Given this list of marker genes Zc3h4, Nelfa, Supt5, Med27, Cdc73, Ccnt2, Scaf8, Supt4a, Ikzf1, Med24, Hnrnpu, Ell2, Wdr43, Med14, Btbd18, Supt4b, Med10, Ccnk, Nelfcd, Wdr82, Ctnnb1, Med25, Leo1, Nelfe (NCBI Gene Id 27632), Cdk12, Nelfb, Med19, Supt6, Hexim1, Med6, Zmynd11, Gtf2f1, Map2k1 (NCBI Gene Id 26395), Cbx7, Med21, Med16, Ccnt1, Ldb1, Med11, Med1, Med20, Med22, Med23, Ncbp1, Sirt6, Ccar2, Ell, Cdk9, Eapp (E2F-associated phosphoprotein), Zmynd8 (NCBI Gene Id 99150), Eaf2, Ncbp2, Med17, Shh, Med7, Med9, Tex24, Med26, Med4, Ezh2, Setd5, Brd4, Med18, Cdk13, Dab2, Ell3, Parp1, Axin1, Eaf1, Med30, Med8, Med31, Recql5, Rnf8, Ercc6, Med29, Rnf168, Kat7, Med28, Med15, Zfp326, Pwwp2b, Chaserr, Pwwp2a, here is a description of the gene set: Any process that modulates the frequency, rate or extent of transcription elongation, the extension of an RNA molecule after transcription initiation and promoter clearance by the addition of ribonucleotides catalyzed by a DNA-dependent RNA polymerase. studied in species Mus musculus Mouse Gene Set: GOBP_REGULATION_OF_DNA_TEMPLATED_TRANSCRIPTION_ELONGATION